The following is a description of a gene set: from publication Chen Y, Wang X (PMID 31504780) Mouse Gene Set: MIR_7222_5P species: Mus musculus Genes predicted to be targets of miRBase v22 microRNA mmu_miR_7222_5p in miRDB v6.0 with MirTarget v4 prediction scores > 80 (high confidence targets)., and this is the list of marker genes: Pcbp2, Unkl, Cry1, Ric1, Bach2, Hmgb2, Otud7b, Gna14 (NCBI Gene Id 14675), Cdca7l, Nr4a3, Elovl6, Pcdh7, Scai, Tbl1xr1, Ryr1, Prickle2, Zfp385b, Enox2, Galk1, Phf6, Ccnt2 (cyclin T2), Pcolce2, Mkrn3, Nsmce2, Plxna4, Rab12, Ctdsp1, Ern1, Nefh, Sorcs1, Zfp677, Rbms1, 4930544G11Rik, Rela, Tardbp, Clasp2 (NCBI Gene Id 97514), Map4k3, Vash2, Slc41a1, Abhd13, Fmnl2, Slc17a6, Ap2m1, Csn1s2b, Atxn7, Galnt3, Nap1l4, Myh9, Sema5a, Dst, Ube2g1, Grm5, Map2k4, Lysmd2, Arl4a, Gpr141b, Vldlr, Ikzf2, Immt, Dot1l, Tmem248, Ptpro, Rab9b, Patj, Tmem255a, Hnf1b (NCBI Gene Id 21410), Med9, Nr0b1, Ltbp1, Hoxd8, Pkd2, Zfyve26, Tenm4, Gpr150, Arl5b, Tprg1l, Ugp2, Sox8, Entpd7, Snap29, Fam76b, Pabpc5, Rgs3, Spred1, Tspyl4, Fnbp4, Insig1, Mapk14, Fbxw7, Rora, Armc1, Phtf2, Gpld1 (NCBI Gene Id 77224), P2ry13, Tmem87a, Ube2e2, Tmem109, Terb1, Rnf138, Fam171a1, Khdrbs3, Lrrc1, Dpp10, Larp7, Nr2f2, Cep164